Given this list of marker genes WDR4P2, USP22, MAP2K5-DT, EIF4G2, SLC3A2, CDC42SE1, TPR, XPO1, PTP4A1, MIR5188, ODC1-DT, DUS3L, UBE3B, PDIA6, KCTD10, H2BC15, NGDN, PTPRZ1, MIR141, WNT11, INTS11, MRPL48 (mitochondrial ribosomal protein L48), AHNAK, CELF3, TEP1, ZNF627, SLC38A4-AS1, GABPB2, PLA2G6 (NCBI Gene Id 8398), MCOLN3, C7orf50 (NCBI Gene Id 84310), MIR200C (microRNA 200c), PCED1B, H3-3B, FAM3D, LINC00620, YWHAE, ENSG00000246308, STAMBPL1, TRIM41, TNRC18, KRT18, SNX24, RPS12, SPRYD3, FAR1-IT1, OGA, FAM234B, SNX8, MAP2K5, METTL1, RAB11A, DPP9 (dipeptidyl peptidase 9), SCN5A, KDM6B, STAT6, ODR4, LINC01342, EEF1AKMT3, H3C9P, ARRDC3, GBP1, PLK1, RNASE4, EML4, PTMS, C2orf42, ODC1, DLGAP4, KAT5, TMEM248, ZNF561, MIR4521, CDK4, BCL3, MTBP, GAR1-DT, MRPS27, ARRDC3-AS1, MALAT1, SIN3B, HJV, UBC, ZNF561-AS1, VTRNA1-1, KCNIP2-AS1, UBE2K, TIA1, SDSL, HECTD2, GPCPD1, ZC3H4, MRPL13, CCNG2 (NCBI Gene Id 901), KMT2E, NADK2, NR4A2, ALOXE3, TMBIM6, KCNN4, LARP4, ZNF76, PHYH, ANG, SNORD101, here is a description of the gene set: Human Gene Set: TFCP2_TARGET_GENES studied in species Homo sapiens Genes containing one or more binding sites for (TFCP2) in their promoter regions (TSS -1000,+100 bp) as identified by GTRD version 20.06 ChIP-seq harmonization. from publication Yevshin I, Sharipov R, Kolmykov S, Kondrakhin Y, Kolpakov F (PMID 30445619)